The following is a description of a gene set: Mouse Gene Set: KUNINGER_IGF1_VS_PDGFB_TARGETS_UP from publication Kuninger D, Kuzmickas R, Peng B, Pintar JE, Rotwein P (PMID 15475267) Peptide growth factors regulate cell fate by activating distinct signal transduction pathways that ultimately influence gene expression. Insulin-like growth factors (IGFs) play central roles in controlling somatic growth and participate in skeletal muscle development and regeneration. In cultured muscle cells, IGF action is critical both for maintaining viability during the transition from proliferating to differentiating myoblasts and for facilitating differentiation. By contrast, platelet-derived growth factor (PDGF) can sustain cell survival but inhibits differentiation. Here we examine the genetic programs that accompany IGF and PDGF action in myoblasts. Through analysis of high-density oligonucleotide arrays containing approximately 36,000 mouse probe sets, we identify 90 transcripts differentially induced by IGF-I, including 28 muscle-specific genes and 33 previously unannotated mRNAs, and 55 transcripts specifically stimulated by PDGF, including 14 unknowns. Detailed study of one IGF-induced mRNA shows that it encodes a protein related to a recently characterized repulsive guidance molecule postulated to regulate neuronal targeting during development. Our results demonstrate the power of transcriptional profiling for gene discovery and provide opportunities for investigating new proteins potentially involved in different aspects of growth factor action in muscle. species: Mus musculus Genes up-regulated in cells (myoblast) by IGF1 vs PDGFB., and this is the list of marker genes: Tnni1, C1qtnf3, Myh3, Sgcg, Pabpc1l, Fndc5, Fst, Smpx, Mymk, Ppfia4, Ncam1, Sgca (sarcoglycan, alpha (dystrophin-associated glycoprotein)), Styxl2, Hspb2, Gatm, Pkia, Actn3, Neil1, Myl1, Cavin2, Atp2a1, Parm1, Cox6a2, Ldb3, Klhl40, Tnnt3, Klhl41, Igf2 (NCBI Gene Id 16002), Smyd1, Myl4, Synpo2l, Tpm1, Lmod2, Atp2b4, Brwd1, Ttn, Myom2, Hjv, Tmem38a, Prkaa2, Usp2, Zbtb18, Erbb3 (erb-b2 receptor tyrosine kinase 3), Daam2, Sox8, Iffo1, Fbxo17, Tnnc1, Mybph, 5430431A17Rik, Unc45b, Actc1, Prkag3, Pgam2, Ryr1, Gpt2, Cnr1, Mylk4, Fzd5, Npnt, Mymx, Xirp1, Fam8a1, Dclk1, Tnnt1, Enah (NCBI Gene Id 98642), Sntb1, A930003A15Rik, Acta1, Ccdc134, Ddc, Tnnt2, Aamdc, Fmo1, Fbxl22, Pygm, Rb1, Srl, Tmem182, Smtn, Myog, Hdac11, Tpm2, Itgb1bp2